Given this list of marker genes TCOF1, COL2A1 (NCBI Gene Id 444981), IDH1, POLR1B, POLR1C, POLR1D, PTH1R, IDH2, PTPN11, MAD1L1, here is a description of the gene set: Multiple enchondromatosis Human Gene Set: HP_MULTIPLE_ENCHONDROMATOSIS species: Homo sapiens